The following is a description of a gene set: Integration of energy metabolism Human Gene Set: REACTOME_INTEGRATION_OF_ENERGY_METABOLISM studied in species Homo sapiens, and this is the list of marker genes: STX1A, GNA11, INS, PRKAR1A, ADIPOR1, GNAQ, ADCY5, GNG7, STXBP1, ACACA, PKLR (NCBI Gene Id 5313), ADCY9, ADCY4 (NCBI Gene Id 196883), PRKAG2, CACNA2D2, PPP2R1B, GNG10, AKAP5, GNAI2, GNGT1, ADCY1, SNAP25 (synaptosome associated protein 25), GNAS, KCNJ11, GLP1R, PPP2R1A (protein phosphatase 2 scaffold subunit Aalpha), ADCY3, GNB5, IQGAP1, MLXIPL, AGPAT1, RAPGEF4, RAPGEF3, CACNA1C, PRKACA, PRKAR2B, GNAI1, GNG2, CHRM3, GNB1, PPP2CA, TKT, GNGT2, GNG12, PRKACB, GCG, CACNB2, ADIPOQ, ITPR1, ITPR3, PFKFB1, GNG11, PRKAR2A, ADCY2, PLCB2, SLC2A1, AHCYL1, KCNG2, GNB4, ADIPOR2, FFAR1, GNG8, PRKAB2, ADCY8, ACSL4, MLX, CD36, GNG13, ABCC8 (NCBI Gene Id 6833), ITPR2, CACNA1E, KCNB1, CACNA1A, VAMP2, GNG4, GNB2, GNG3, RAP1A, PLCB1, TALDO1, ADCY6, MARCKS, PLCB3 (NCBI Gene Id 5331), PPP2CB, PRKCA, KCNS3, GNA14, PRKAA2, PRKACG, PPP2R5D, ACLY, ADCY7, ADRA2C, ACACB, CACNB3, FASN, ACSL3, GCGR, ADRA2A, KCNC2, GNG5, SYT5, SLC2A2, GNA15, CACNA1D, GNB3, PRKAR1B, STK11